The following is a description of a gene set: studied in species Homo sapiens from publication Jura J, Wegrzyn P, Korostyński M, Guzik K, Oczko-Wojciechowska M, Jarzab M, Kowalska M, Piechota M, Przewłocki R, Koj A (PMID 18498781) Human Gene Set: GSE8515_CTRL_VS_IL1_4H_STIM_MAC_DN Genes down-regulated in comparison of untreated macrophages versus those treated with IL1. Using whole-genome Affymetrix microarrays (HG-U133A), we characterized the transcriptome profile of cultured human macrophages stimulated for 4 h with interleukin 1 (IL-1) or interleukin 6 (IL-6). We found that, in distinction to liver cells, IL-1 is much more potent than IL-6 in modifying macrophage gene expression, although considerable heterogeneity in response of macrophages deriving from individual blood donors was observed. The obtained results permitted to identify a large number of cytokine-responsive genes. coding for proteins of unknown function that are now being studied in our laboratory. They may represent novel targets in the anti-inflammatory therapy., and this is the list of marker genes: CENPS, CCL20, IGFALS (NCBI Gene Id 3483), CDH19, USP13, CELF3, RAPGEF6, RABIF, CCR7, ICAM1, RHBDF2, AURKAIP1, PTBP3, HOOK1, HDAC7, BTG3, CFAP43, MAPRE3, ATF5, IGLL3P, PIGH, LIMK2, MAPKAPK5, PPIF, LCP2, PRKCD, ATXN2L, EBI3, KANK1, TMC7, MAPK8, CCL4, GYPC, TUBD1, CDKL2, DYNC1H1, CEBPB, RC3H2, CDH4, ARFRP1, DRG2, FOXO4, PLK3, IL6 (NCBI Gene Id 3569), SLC37A1, P2RX7, RRS1, PAFAH1B2, WDR3, B4GALT6, TBC1D2B, ATAD3A, CXCL1, SLC35F5 (solute carrier family 35 member F5), SIK3, RAP2C, GPR171, PHAF1, UBE2Z, GADD45B, POLH, ZNF711, WNT5A, ASB6, JUNB, TNIP1, NFE2L1, ZNF33B, MRGBP, THNSL2, IL15RA, RELB, TNFAIP2, VPS4A (vacuolar protein sorting 4 homolog A), NDUFB4, CCL16, BID, YRDC, EIF4B, LRP8, NFKB2, FSCN1, ZHX2, KDM4D, MYO15A, SERTAD3, MARK1, SLC25A44, CD82, GDF2, ZC3H12A, CDKN2B, LINC00472, ENSG00000284948, GAL3ST1, PUS3, ELMO3, ROM1, EHD1, MARCKSL1, LIF, PAXIP1, AADAC, EMX2, AURKB, KEAP1, BSDC1, BBC3, TRIP10, RNPS1, ST3GAL4, HTR6, REL, FJX1, PAGE4, PTX3, NT5C, WTAP, PSMC4, NECAP2, IGHA1, DENND5A, CSRNP3, NIN, ASAP2, RCAN1, TRAF1, EZR, C8orf44, RNF115, SYCE1L, MBL2, GRAMD2B, SDK2, KDM6B, FAM182A, UXT, MGP, B4GALT5, RUNDC3B, TNIP2, NET1, HP1BP3, BUD23, SRRM2, NFKB1, MOCS3, PILRA, NOP16, PLXNA1, SDC4, PLEK, TNIP3, BCL3, FBXW7, MATN3, MCM3AP, SYNGR3 (synaptogyrin 3), TNNI1, CLDN5, SEC61G, TNFAIP6, PPP3CC, CXCL3, BRD1, VAV1, SERPINB2, UTP25, CNGB1, GJD2, CXCL6, MAMLD1 (NCBI Gene Id 653998), ABTB2, IER3, TNF, SINHCAF, NFKBIE, EGR3, SLC2A6, MATN4, IQSEC2, CHST2, TNFAIP3, HCAR3, ACSL1, TET3, CD70, NFKBIA, HCK, CXCL2, AMPD3, KRT8P12, TUT1, ARL2BP, CXCL8 (C-X-C motif chemokine ligand 8), KLRC4, MAGOH2P